Given this list of marker genes PDE4DIPP4, NBPF26, RPL22P6, PDE4DIPP2, H3P4, ENSG00000295970, PPIAL4A, H2BP1, FAM72B, LINC00623, MTIF2P1, NBPF8, NOTCH2NLR, ENSG00000295994, SRGAP2-AS1, SRGAP2C, LINC02798, LINC01691, EMBP1, RNVU1-4, PFN1P2, FCGR1BP, RNVU1-19, here is a description of the gene set: Human Gene Set: chr1p11 species: Homo sapiens